Given this list of marker genes SAMD1, KDM1A, PHF2, JPX, KMT2A, RLF, DNMT3L, L3MBTL3, PHF8, DYRK1A, here is a description of the gene set: Human Gene Set: GOBP_NEGATIVE_REGULATION_OF_CHROMATIN_ORGANIZATION species: Homo sapiens Any process that stops, prevents or reduces the frequency, rate or extent of chromatin organization.